Given this list of marker genes NMNAT1, NAMPT, ASPDH, NADK (NCBI Gene Id 65220), QPRT, NADSYN1, NMRK1, PDXK, KYNU (kynureninase), KMO, IDH2, NADK2, ACMSD, PSAT1, IDO1, NMNAT2, HAAO, NMRK2, PNPO, NMNAT3, AFMID, NAPRT, IDO2, here is a description of the gene set: The chemical reactions and pathways resulting in the formation of a pyridine-containing compound, i.e. any compound that contains pyridine or a formal derivative thereof. Human Gene Set: GOBP_PYRIDINE_CONTAINING_COMPOUND_BIOSYNTHETIC_PROCESS species: Homo sapiens